Given this list of marker genes Nmur2, Lin28a, Dner, Exosc4, Cherp, Gna13, Phox2b, Slc25a40, here is a description of the gene set: Mouse Gene Set: MIR_598_3P species: Mus musculus from publication Chen Y, Wang X (PMID 31504780) Genes predicted to be targets of miRBase v22 microRNA mmu_miR_598_3p in miRDB v6.0 with MirTarget v4 prediction scores > 80 (high confidence targets).